Given this list of marker genes TSEN54, TSEN15, SEPSECS, TSEN34, VRK1, TSEN2, here is a description of the gene set: Underdevelopment of the ventral portion of the pons. Hypoplasia of the ventral pons Human Gene Set: HP_HYPOPLASIA_OF_THE_VENTRAL_PONS species: Homo sapiens